The following is a description of a gene set: A process in which a protein is transported to, or maintained in, a location within a cilium. Human Gene Set: GOBP_PROTEIN_LOCALIZATION_TO_CILIUM studied in species Homo sapiens, and this is the list of marker genes: RAB11A (NCBI Gene Id 8766), BBS1, DNAH11, TTC21B, BBS9, EHD1, IFT20, ATP6V1D, ROPN1, PCARE (photoreceptor cilium actin regulator), SPATA7, IFT80, RAB8A, RAB29, ASAP1, DZIP1, TULP1, CC2D2B, TBC1D32, RAB11FIP3, TTC21A, MICALL1, ARL6, ARL3, FSIP2, TCTN2, CCDC40, ZNF423, GFY, NPHP4, CCDC88A, TULP2, ENTR1, ZDHHC3, RABEP1, CSNK1D, ARL13A, EFCAB7, DYNC2H1, CCDC66, GAS8, RPGR, WDR35, CFAP58, ZMYND10, FAM149B1, CC2D2A, INPP5E, GDI2, TUB, IFT122, IFT140 (intraflagellar transport 140), ARF4, ROM1, DNAAF11, LZTFL1, TMEM107, SNX10, INVS, ARL13B, CEP78, WDR19, DZIP1L (NCBI Gene Id 199221), IFT56, ROPN1B, CROCC, MAPK15, CCDC39, ODAD4, BBIP1, TCTN1, CDK20, BBS4, TULP3, GSK3B, GGA1